The following is a description of a gene set: Aplasia/Hypoplasia of the tragus Human Gene Set: HP_APLASIA_HYPOPLASIA_OF_THE_TRAGUS studied in species Homo sapiens Aplasia or developmental hypoplasia of the tragus., and this is the list of marker genes: NUP188, SF3B2, KCTD1, SMCHD1, GLI2, RAP1B, EFTUD2, KAT6A (NCBI Gene Id 7994)